Given this list of marker genes NTRK1, PCSK6, NGFR, FURIN, SORT1, here is a description of the gene set: studied in species Homo sapiens Human Gene Set: GOMF_NERVE_GROWTH_FACTOR_BINDING Binding to nerve growth factor (NGF).